The following is a description of a gene set: Human Gene Set: GOBP_SPONTANEOUS_SYNAPTIC_TRANSMISSION The low level of synaptic transmission that occurs via spontaneous neurotransmitter release into the synaptic cleft in the absence of a presynaptic action potential. species: Homo sapiens, and this is the list of marker genes: STX1B, CBLN2, RPH3A, DOC2A, SYT1, SLC12A2, APP, DOC2B, RIMS2, AGER, PRKN, NSG1, ITGB1